Given this list of marker genes Crebbp, Sdk1, Drd2, Fosb, Fadd, Snca, Nos1, Cdk5, Parp1, Crhr1, Bdnf, Homer2, Adra1b, Drd1, Htr2a, Ppp1r1b, Homer1, Drd4, Oprk1, Slc6a4 (solute carrier family 6 (neurotransmitter transporter, serotonin), member 4), Ehmt2, Drd3, here is a description of the gene set: Mouse Gene Set: GOBP_BEHAVIORAL_RESPONSE_TO_COCAINE Any process that results in a change in the behavior of an organism as a result of a cocaine stimulus. species: Mus musculus